Given this list of marker genes DHFR, RRM1, NPAT, CDC25B, SLBP, CCNG2, TYMS, MSH2, CDKN1A, CCNE1, CDKN2D, CDC20, CENPA, CENPF, CCNE2, AURKA, CDKN3, CDK1, PLK1, CDC25C, CCNF, TOP2A, CDKN2C, CCNA2 (NCBI Gene Id 890), BIRC5, E2F5 (E2F transcription factor 5), RRM2, RACGAP1, CDC45, CDC6, KIF20A, MCM2, CCNB1, E2F1, BRCA1, CCNB2, MCM6, BUB1, PCNA, BRCA2, BUB1B, NASP, CDC25A, CKS2, here is a description of the gene set: A list of known cell cycle regulated genes that was compiled from the literature by the authors. studied in species Homo sapiens from publication Whitfield ML, Sherlock G, Saldanha AJ, Murray JI, Ball CA, Alexander KE, Matese JC, Perou CM, Hurt MM, Brown PO, Botstein D (PMID 12058064) Human Gene Set: WHITFIELD_CELL_CYCLE_LITERATURE The genome-wide program of gene expression during the cell division cycle in a human cancer cell line (HeLa) was characterized using cDNA microarrays. Transcripts of >genes showed periodic variation during the cell cycle. Hierarchical clustering of the expression patterns revealed coexpressed groups of previously well-characterized genes involved in essential cell cycle processes such as DNA replication, chromosome segregation, and cell adhesion along with genes of uncharacterized function. Most of the genes whose expression had previously been reported to correlate with the proliferative state of tumors were found herein also to be periodically expressed during the HeLa cell cycle. However, some of the genes periodically expressed in the HeLa cell cycle do not have a consistent correlation with tumor proliferation. Cell cycle-regulated transcripts of genes involved in fundamental processes such as DNA replication and chromosome segregation seem to be more highly expressed in proliferative tumors simply because they contain more cycling cells. The data in this report provide a comprehensive catalog of cell cycle regulated genes that can serve as a starting point for functional discovery. The full dataset is available at http://genome-www.stanford.edu/Human-CellCycle/HeLa/.